Given this list of marker genes Calr, Astl, Padi6, Nlrp5, Myh9, Hexb, here is a description of the gene set: A secretory vesicle that is stored under the cell membrane of an egg. These vesicles fuse with the egg plasma membrane as part of egg activation and are part of the block to polyspermy. Mouse Gene Set: GOCC_CORTICAL_GRANULE species: Mus musculus